The following is a description of a gene set: studied in species Mus musculus Genes up-regulated in MEF cells (embryonic fibroblast) isolated from NRAS knockout mice. Human Gene Set: CASTELLANO_NRAS_TARGETS_UP from publication Castellano E, De Las Rivas J, Guerrero C, Santos E (PMID 16909116) We characterized differential gene expression profiles of fibroblast cell lines harboring single or double-homozygous null mutations in H-ras and N-ras. Whereas the expression level of the individual H-, N- and K-ras genes appeared unaffected by the presence or absence of the other ras loci, significant differences were observed between the expression profiles of cells missing N-ras and/or H-ras. Absence of N-ras produced much stronger effects than absence of H-ras over the profile of the cellular transcriptome. N-ras(-/-) and H-ras(-/-) fibroblasts displayed rather antagonistic expression profiles and the transcriptome of H-ras(-/-) cells was significantly closer to that of wild-type fibroblasts than to that of N-ras(-/-) cells. Classifying all differentially expressed genes into functional categories suggested specific roles for H-Ras and N-Ras. It was particularly striking in N-ras(-/-) cells the upregulation of a remarkable number of immunity-related genes, as well as of several loci involved in apoptosis. Reverse-phase protein array assays demonstrated in the same N-ras(-/-) cells the overexpression and nuclear migration of tyrosine phosphorylated signal transducer and activator of transcription 1 (Stat1) which was concomitant with transcriptional activation mediated by interferon-stimulated response elements. Significantly enhanced numbers of apoptotic cells were also detected in cultures of N-ras(-/-) cells. Our data support the notion that different Ras isoforms play functionally distinct cellular roles and indicate that N-Ras is significantly involved in immune modulation/host defense and apoptotic responses., and this is the list of marker genes: FNDC3A (NCBI Gene Id 22862), PCBD2, P3H4, ANXA8L1, PERP, VNN1, IFI27L2, SCX, UGT1A10, SARDH (NCBI Gene Id 8017), IRGM, CRABP2, USP18, CCNG1, PYHIN1, NQO1 (NAD(P)H quinone dehydrogenase 1), TULP4, BAX, HLA-B, SLC66A3, TUBB2A, CRIP2, IFIH1, SERPINE2, MGP, PSMB8, IL13RA1, ZNF32, MEST, B2M, ENPEP, ERCC5, ZNF703, CRYBG1, IL1RN, GJA1 (NCBI Gene Id 7953), IFIT1B, LSP1, PLSCR1, SDC1, MMP13 (NCBI Gene Id 4322), RAMP2, DLX5, CX3CL1, CLEC11A, ADCY2, ANXA4 (NCBI Gene Id 307), AK1, TRIM11, PLTP (NCBI Gene Id 5360), STAT1, GBP2, LBP, PTX3, NSG1, PENK, NPR3, TMEM43, KCTD12, PHLDA3, TAP1, ACADM, PPP1R7, CFH, EPHX1, EXOC4, ITIH2, LCN2, IFI35, ISG15, YIF1A, PON3